The following is a description of a gene set: Mouse Gene Set: GOCC_BASEMENT_MEMBRANE species: Mus musculus A collagen-containing extracellular matrix consisting of a thin layer of dense material found in various animal tissues interposed between the cells and the adjacent connective tissue. It consists of the basal lamina plus an associated layer of reticulin fibers., and this is the list of marker genes: Col4a4, Col18a1, Gsto1, Ang5, Nid2, Efemp2, P3h1, Col22a1, Hmcn1, Vwa2, Col6a3, Cd151, Entpd1, Lad1, Tgfbi, Loxl1, Vtn, Timp2, Tgfb2, Col28a1, Frem2 (NCBI Gene Id 71477), Mmrn2, Vegfa, Pxdn, Agrn, Efna5, Col15a1, Acta2, Lamc2, Anxa2, Egfl6, Amtn, Col8a2, Thbs2, Col4a5, Nid1, Lama3, Matn2, Fgf9 (NCBI Gene Id 252883), Cfdp1, Lamb1, Rpsa, Megf9, Col4a6, Col2a1, Frem3, Tnc (NCBI Gene Id 21923), Timp1, Fbln1, Serpinf1, Runx1, Ntn4, Fbn1, Dlg1, Rell2, Col7a1, Vwa1, Dag1, Col4a2, Spn, Frem1, Loxl2, Col24a1, Fn1, Marco, Itgb1, Entpd2, Ntn1, Nphs1, Lamb3, Timp3, Col13a1, Col5a1, Tinag, P3h2, Ptn, Ntn3, Amelx, Lamc1, Smoc1, Col9a3, Itga6, Adamts1, Lamb2, Pmp22, Smoc2, Col4a1, Col4a3, Col8a1, Hmcn2, Npnt, Col16a1 (collagen, type XVI, alpha 1), Acan, Lama5, Ush2a, Lama4, Ccdc80, Lama1, Ang, Papln, Egflam, Alb, Ang2, Lamc3, Hspg2, Thbs4, Col17a1, Cask, Ang6, Efemp1, Cst3, Itgb4, Sparc, Col6a1, Vwc2, Lama2, Smc3, Ang4, Ntn5, Trf (NCBI Gene Id 22041), Ache, Fras1